Given this list of marker genes Prkd2 (protein kinase D2), Thbs1, Fgfbp1, Shisa2, Nrxn1, Fgfrl1, Wnt5a, Nog, Spry1, Pdgfb, Lrit3, Gpc1, Creb3l1, Spry2, Itgb1, Fgfbp3, Fam20c, Dstyk, Runx2, Nptn, Smoc2, Sulf2, Sulf1, Prdm14, Wnt4, Apln, Fuz, Ctnnb1, Spry4, Ngfr, Tcf7l2, Ofd1, Hhip, Gata3, here is a description of the gene set: Mouse Gene Set: GOBP_REGULATION_OF_FIBROBLAST_GROWTH_FACTOR_RECEPTOR_SIGNALING_PATHWAY Any process that modulates the frequency, rate or extent of fibroblast growth factor receptor signaling pathway activity. species: Mus musculus